The following is a description of a gene set: The lipid bilayer surrounding any of the thin, flattened compartments that form the central portion of the Golgi complex. Mouse Gene Set: GOCC_GOLGI_CISTERNA_MEMBRANE studied in species Mus musculus, and this is the list of marker genes: Fut7, Gal3st2, B4galt1, St3gal2, Iigp1, Abo, Psenen, Fut11, Csgalnact1, Chsy3, Chpf, Golim4, Nsg1, Galnt3, B4galt7, Golga3, Sar1a, Gpr89, B4galt2, Csgalnact2, B3galt6, St6gal1 (NCBI Gene Id 224053), Asap2, Tmed2, Golga2, Fut1, B4galnt3, Tmem115, Slc30a5, Galnt1, Gal3st3, Cant1, Nucb1, Tmem87b, Cog3, Uxs1, St3gal3, A3galt2, Scfd1, Bcap31, B4galt5, Nsg2, Atp2c1, Fut4, St3gal4 (NCBI Gene Id 20443), St3gal1, Sec1, Fut2, Tmed3, Sort1, Inpp5e (NCBI Gene Id 64436), Galnt2, 4930568D16Rik, Aph1a, B4galnt4, Fut8 (NCBI Gene Id 53618), Rab21, Hace1, Slc30a7, Golph3, Chsy1, Sar1b, B4galt6, Arap1, Tmem87a, Pitpnm1, B4galt3, Mob4, St6gal2, Nagpa, Ggta1, Golph3l